Given this list of marker genes COL12A1, TCF21 (transcription factor 21), PARD6A, OTX2, ELAPOR1, L3MBTL2, CADM1, REEP6, NHLH1, KCNB1 (potassium voltage-gated channel subfamily B member 1), SORCS2, EPHA2, AMD1, AGAP3, TRIM63, LARP1B, SMPD3, ELL3, RIMKLA, MDGA1, EXTL3, CREBBP, EXOC6, TUBAL3, NRK, LARP4, CRELD1, PPP1R21, FCMR, WNT9A, LYPD1, ACAP1, PLEC (plectin), RELCH, TNFRSF21 (NCBI Gene Id 51323), SERF2, DLG1, CCND2, IRF1, SYT4, UNC13B, MRGPRG-AS1, PRR15, RTL9, ERP29, SNX17, IGF2-AS, OXR1, GFRA1, INVS, DOCK9, DLG2, PAQR5, PPP2R5C (protein phosphatase 2 regulatory subunit B'gamma), IDE, TJP1, IL17C, TMEM116, PPTC7, PKN1, JADE1, GNG8, ARHGEF38, IGFBP5, ZNF710, PADI4, GNAS, PDGFB, MAP7, PIM2, ALX3, PARP8, MAPT, FOSL1, TSPAN13, REM2, AP1S2, BRSK1, TLNRD1, AJUBA, KCNIP2, TMEM88, PTCHD1, CDH2, BRINP3, CALB1, ADRA2C, HSALR1, NPEPPS, NUMBL, GNG13, CAMK1D, HIPK4, CHD6, NBEA, PRKAG1, ID1, WNT3A, CRABP2, WWC1, B4GALT6, TRAPPC13, PPP4R3B, NDUFAF3, ATXN7L2, DMTF1, RPL28, RANBP9, KAZALD1, SEMA6A, CKM, SRM, PAX9 (NCBI Gene Id 5083), PCDHA6, PTPRJ, ZRANB1, WTAP, MYCL, SPMIP9, EIF2B4, FGF8, PRKCZ, SLC23A2, STMN2, IMPDH1, RIPK4, VDR (vitamin D receptor), BARHL1, ADCY8, RIN1, HCRTR2, JOSD1, FBXW9, CCNYL1, KMT2E, WNT6, MYADM, FGR, CHRND, GATA2, NR2E1, BICDL1, MLLT6, ARL5B, PCDHA1, JMJD6, CCDC78, TNFSF13, RPUSD4, MAP3K14, RNF183, IGF2, E2F1, ELMO1, GRIN1, MTUS1, CYP26A1, C2CD2L, HAPLN2, DNAJC11, HOXD10, ZNF133, PPP1R16B, ESRP2, AP5B1, CLSTN3, RAP1GAP2, BCL6, INHA, LMO1, FGF11, NSG2, GPR156, DCLK2, STARD13, PRDM10, RBP5 (NCBI Gene Id 83758), DDB1, SOX14, ERBB3 (erb-b2 receptor tyrosine kinase 3, NCBI Gene Id 619500), FSCN2, CA7, SH2D3C, CITED2, MAP3K3, SLC38A3, CPNE1, DNAH17, TMT1B, KCNN3, ADAM12, KIF5B, LRATD2, DALRD3, TRIM23, GJB4, MAZ, TKFC, RARG, PSIP1, ZNF800, PPM1A, ITGA7, LRRC8D, ARRDC3, TSPAN2, CALM3, LRRN1, BHLHE22, DCTN1, HMGN2, NFE2, DNMT3A, VPREB1, ZNF521, KEAP1, ATP1B1, ANKRD13B, EPB41, SLC4A1, HID1, DOK7, HOXA11, HIF3A, CD79A, PCDHA10, PCSK4, ANP32A, EDA, RPS6KB1, FGF12, CCNL2, TGFB3, NEURL1, SPEG, JAG1, TRIM8, PLEKHH3, SHISA7, SHKBP1, SYNE1, MYL11, BNC2, TAFA4, AGAP2, EXOC3L2, HES6, RORC, OSR1, SMTNL2, EVX1, BCL9L, GAB2, FGF7, COMMD5, ATP2B3, CNNM2, FHL3, NRG2, MAP3K4, MYO1E, RUNX1, NR3C2, LRP10, COL26A1, here is a description of the gene set: species: Homo sapiens Genes having at least one occurrence of the motif CNNCAGGTGBNN in the regions spanning 4 kb centered on their transcription starting sites. This matches the LMO2 transcription factor binding site V$LMO2COM_01 (v7.4 TRANSFAC). Human Gene Set: LMO2COM_01